Given this list of marker genes MIR181B1, GATA2, CLEC7A, FCGR2C, RAB4A, CBLB, PYCARD, TNK2, SELE, SPHK1, NCDN, DGKQ, CD151, EHD4, CNN2, AZU1, NECAB2, C3, RAB21, RACK1, HMGB1, ANKRD13D, MAGI2, BTK, MIB1, RUFY1, FCGR1A, CCL19, LRRK2, ITGAV, SNX17, MCTP1, CLU, NR1H2, LYAR, PRKCG, STAT3, NCKAP1L, ANGPT1, HFE, RAB31, CCR7, IL4, SLC11A1, AP2M1, HPCA, CD300A, MIR20A, DLL1 (delta like canonical Notch ligand 1), TGM2, LRPAP1, PICK1, OPHN1, PRTN3, FCN1, LDLRAP1, PCSK9 (NCBI Gene Id 50983), FCGR2A, SOD1, TOR1A (torsin family 1 member A), FCGR2B, COLEC10, H1-1 (NCBI Gene Id 3024), DNAJC6, EEF2K, MIR92B, PRKACA, MIR17, CSK, GAS6, STON1, SYT4, PPT1, TUB, RAB27A, CDH13, FCN3, BTBD9, ARF1, TSG101, C2, ABCA7, PRKD1, PPP3CB, DKK1, SFRP4, SRC, RIT2, ABL1, CYBA, NRG1, CD177, TLR2, LMAN2, SIRPA, PTPN1 (protein tyrosine phosphatase non-receptor type 1), ACTG1, APOE, INSR, APOC3, ARFGAP1, PACSIN1, IL2RG, SPACA3, TAMALIN, SH3GL3, ROCK1, RAB5C, PICALM, PROM2, ARRB1, CD22, CD14, UNC119, CBL, CD47, PRKN, WNT5A, RABGEF1, ITSN1, FGR, SUSD4, LRSAM1, NLGN1, APOC2 (apolipoprotein C2), APOA2, STX1B, SIRPB1, APLN, SCARB1, AP2S1, RAP1A, RIN3, HIP1R, EGF, DGKD, ITGB3, GH1, MDM2, VAMP4, PLA2G5, ACTB, AXL, CDC42, ALOX15, ANKRD13A, MKLN1, RALA, C4B, ANXA2, PACSIN3, ATXN2, DTNBP1, NEU3, MIR199A1, PPP3CA, PTX3, COLEC11, SYT7, DLG4, WASL, SDCBP, ARAP1, PARK7, PACSIN2, ANXA2P2, SNX12, APOA5, ATAD1, PLSCR1, DRD4, MIR185, ANKFY1, RSPO1, DYSF, PIK3CB, ARPC3, DRD2, FLOT1, RAC1, SMAP1, BMP2K, LILRB1, SNAP91, LRRTM2, LRRTM1, CD36, SCRIB, MIR205, HIP1, ZFYVE16, ANKRD13B, NUMB, SMPD1, VPS28, LGALS3, SYT17, CD300LF, CALM3 (calmodulin 3), SNX3, CALY, PPP3CC, FCER1G, HCK, ADIPOQ, CFP, EPHA3, TBC1D5, CD63, RUFY2, USP6, BICD1, AHSG, CLIP3, SYT11, RNF220, ATG5, PPP3R1, CBLL1, IFNG (NCBI Gene Id 3458), GSG1L, FMR1, SYNJ2BP, ANO6, NTF3, CAV1, LPAR1, VEGFA, APPL1, USP46, RAB4B, BCR, TREM2, RABEP1, CCDC32, TFR2 (NCBI Gene Id 7036), AP2A1, MBL2, EFNB2, IL15RA, FCN2, HAMP, MIR183, MYO18A, SLC17A7, CCL21, PTPRJ, MERTK, ABL2, GREM1, ABCA13, ABCA2, BIN1, APOA1, ARRB2, VAC14, RAB5B, PLCG2, PLLP, APELA, CCL2, ARF6, APP, IL15, ITGA2 (integrin subunit alpha 2), FCGR1BP, MYLK, CAMK1D, STON2, PIP4P2 (phosphatidylinositol-4,5-bisphosphate 4-phosphatase 2), TSC2, RUBCN, UBQLN2, DAB2, USH1G, AHI1, B2M, ATG3, WNT3A, MIR27B, APOC1, SIRPG, SNX33, ARC, NEDD4L, MTMR2, TGFB1, SYK, DOCK2, STAP1, SNX9, FPR2, SH3GL2, CAV3, WDR54, NR1H3, TULP1, CALR, LRP1, CLN3, SNCA, APLNR, SFTPD, APPL2, PTPRC, LETMD1, SGIP1, VTN, F2RL1, SCAMP5, TF, C4A, AP2B1, GPC3, RAP1GAP, IL2RB, SERPINE1, AAK1, here is a description of the gene set: species: Homo sapiens Any process that modulates the frequency, rate or extent of endocytosis. Human Gene Set: GOBP_REGULATION_OF_ENDOCYTOSIS